The following is a description of a gene set: The process aimed at the progression of an oligodendrocyte over time, from initial commitment of the cell to a specific fate, to the fully functional differentiated cell. An oligodendrocyte is a type of glial cell involved in myelinating the axons in the central nervous system. species: Homo sapiens Human Gene Set: GOBP_OLIGODENDROCYTE_DEVELOPMENT, and this is the list of marker genes: ZNF488, HES5, EIF2B1, ASCL1, B4GALT6, CNTNAP1, GSTP1, MYRF, TPPP, EIF2B4, EIF2B3, NCSTN, ABCA2 (NCBI Gene Id 23153), ERCC2, PRDM8, TGFB1, ID2, PTEN, NSUN5, MED12, MAL, B4GALT5, CNTN1, CNTN2, SOX11, WASF3, GPM6B, CERS5, NKX2-2, FA2H, SOX10, OLIG1 (oligodendrocyte transcription factor 1), MAG, TENM4, CERS6, EIF2B2, CCDC39, KCNJ10, PLP1, ID4, SHH, LPAR1, MIR26A1, NKX6-2, EIF2B5, LYN, MIOS, CLU, CD9